The following is a description of a gene set: studied in species Homo sapiens An endocytosis process that results in the uptake of liquid material by cells from their external environment; literally 'cell drinking'. Liquid is enclosed in vesicles, called pinosomes, formed by invagination of the plasma membrane. Human Gene Set: GOBP_PINOCYTOSIS, and this is the list of marker genes: EHD4, MAPKAPK2 (MAPK activated protein kinase 2), PYCARD, KCNN4, AXL, APPL2, CARMIL1, CAV1, SNX33, ANKFY1, RAB34, MAPKAPK3, PPT1, NR1H2, SNX5, PROM2, AHSG, STX1B, CDC42, APPL1 (NCBI Gene Id 26060), CLN3, DOCK2, NR1H3